The following is a description of a gene set: An inflammasome complex that consists of two components, NLRP1 (NALP1) and caspase-1 or caspase-5. The exact mechanisms of NLRP1 activation remain obscure, but potassium ion efflux appears to be essential. studied in species Mus musculus Mouse Gene Set: GOCC_NLRP1_INFLAMMASOME_COMPLEX, and this is the list of marker genes: Pycard, Nlrp1a, Nlrp1b, Casp12, Casp1, Casp4